The following is a description of a gene set: from publication Nurieva RI, Chung Y, Hwang D, Yang XO, Kang HS, Ma L, Wang YH, Watowich SS, Jetten AM, Tian Q, Dong C (PMID 18599325) Genes up-regulated in comparison of Th1 cells versus Th17 cells. Human Gene Set: GSE11924_TH1_VS_TH17_CD4_TCELL_UP studied in species Homo sapiens After activation, CD4+ helper T (Th) cells differentiate into distinct effector subsets. Although chemokine (C-X-C motif) receptor 5-expressing T follicular helper (Tfh) cells are important in humoral immunity, their developmental regulation is unclear. Here we show that Tfh cells had a distinct gene expression profile and developed in vivo independently of the Th1 or Th2 cell lineages. Tfh cell generation was regulated by ICOS ligand (ICOSL) expressed on B cells and was dependent on interleukin-21 (IL-21), IL-6, and signal transducer and activator of transcription 3. However, unlike Th17 cells, differentiation of Tfh cells did not require transforming growth factor b (TGF-b) or Th17-specific orphan nuclear receptors RORa and RORg in vivo. Finally, naive T cells activated in vitro in the presence of IL-21 but not TGF-b signaling preferentially acquired Tfh gene expression and promoted germinal-center reactions in vivo. This study thus demonstrates that Tfh is a distinct Th cell lineage., and this is the list of marker genes: AMHR2 (anti-Mullerian hormone receptor type 2), TCF7L2, HLA-C, TLCD3B, MALAT1, TRIM25, CWF19L1, DMRTB1 (NCBI Gene Id 63948), DIS3, PNMT, DNAJB8, UCN, INHBB, BCL2A1, CBLB, UBE3A, TSC22D1, NOP9, EEF1D, AGPAT4, KRT6A (NCBI Gene Id 93086), INSYN2A, C3orf80, CLEC4M, LAT, RADIL (NCBI Gene Id 55698), SLFNL1, B2M, NABP1, MYEF2, NKX2-5, ISY1, CACNG1, IFRD2, MSANTD1 (NCBI Gene Id 345222), HEBP2 (heme binding protein 2), ZYG11A, PDCD2L, GPR27, BARX1 (BARX homeobox 1), PFKFB3, SPRY4, MED7, SLC25A25, CEP83, PARD3 (par-3 family cell polarity regulator), GTF3A, AGAP1, MAP3K21, FAM181B, RGS9BP, ZFPM1, GCH1, DHPS, MORC2, KRT33A, UBXN2B, PRODH2, SAYSD1, KCTD1, FAM83F, ATXN7L2, ODAD3, DMRTA2, PTPRCAP, INAVA, LRRC24, PRAP1, SH3BP2, TES, MFSD14A, LRRC52, MS4A6A, MTUS1, GRIA4, SLC5A11, DCLK1, EXTL3, MAD2L2, ERRFI1, OSMR, PITX1, CYS1, SPRR2A, KCNIP4, KIF24, OTOS, CSF2, CPA5, TASOR, ERCC3, LZTS2, CENPJ, SLC4A3, DUSP9, PMS1, IGSF21, AGFG1, LRG1, UHMK1, ADD2, MUTYH, TPD52L1, B4GALNT1, CELF3, MPPED1, SHANK3, LRRC46, EPSTI1, DTNB, ADCY8, SALL2, OTULIN, TMEM199, METTL2B, AFP, CD99L2, CRLF1, CES5A, IRGC, GALR3, GPR87, ZNF354C, AFG2B, CHCHD3, SRRD, PROX2, SUB1, LPIN3, BABAM1, CLDN14, ADRA2B, CNTN3, E4F1, DCPS, BST2, COPG2, CABLES1, CEL, TTBK2, CGA, KCNQ2, FGFR3, BMP7, IGSF1, RGS9, BABAM2, C2orf49, EVX1, RALGPS1, LIFR, ESR2, MLXIPL, RGS3, MTUS2, SLC35F1, NGB, DCAF12L1, PIGT, CAMP, VPREB1, AMDHD2, MMD2, DIO1 (iodothyronine deiodinase 1), LCMT1, SLA2, CNNM2, SRP72, HABP2, CDH6, MAGOHB (NCBI Gene Id 55110, mago homolog B, exon junction complex subunit), AGMO, CNTN2, C9orf152, GTF2F2, OXGR1, SST, CCL21, RPE, UGCG, FRZB, XDH, CD247 (CD247 molecule, NCBI Gene Id 919), SEL1L3, NHSL1, TSG101, NRXN1, TSR3, UCP1, NWD1, DNER, FHL2, FOXQ1, OC90, ACTL10, SLC7A6OS, ATOH8, REL, RASL12, PRPS2